The following is a description of a gene set: Breast hypoplasia Underdevelopment of the breast. Human Gene Set: HP_BREAST_HYPOPLASIA species: Homo sapiens, and this is the list of marker genes: SOX10, SPRY4, TAC3, FEZF1, FGFR1, HESX1, NSMF, NDNF (NCBI Gene Id 79625), WDR11, ANTXR1, SEMA3A, EFNB1, GNRHR, KISS1R, CDT1, ACTB, IKBKG, DCC, YY1, FLRT3, GNRH1, ORC4, IL17RD, TBX3, CHD7, ANOS1, HS6ST1, DUSP6, POC1A, FSHB, TP63, TACR3, USP9X, MAF, NHLH2, PROK2, PROKR2, ORC6, FGF17, ORC1, CCDC141, KISS1 (KiSS-1 metastasis suppressor), TWIST2, NIN, ESR1, FGF8